Given this list of marker genes AKT1, AAAS (NCBI Gene Id 8086), CYP11A1, SERPINA6, CYP11B1, TRAPPC11, BAP1, GLI3, SMARCB1 (SWI/SNF related, matrix associated, actin dependent regulator of chromatin, subfamily b, member 1), TERT, SMO (smoothened, frizzled class receptor), STAR, POR, NR0B1, NNT, HSD3B2, CYP17A1, GATB, MRAP, PIK3CA, ABCD1 (ATP binding cassette subfamily D member 1), TXNRD2, MPV17, QRSL1, MC2R, PCSK1, NF2, SMARCE1, ROBO1, TBX19, GATC (glutamyl-tRNA amidotransferase subunit C), SUFU, NFKB2, POMC, TRAF7, GMPPA, PDGFB, here is a description of the gene set: Human Gene Set: HP_DECREASED_CIRCULATING_CORTISOL_LEVEL species: Homo sapiens Decreased circulating cortisol level Abnormally reduced concentration of cortisol in the blood.